Given this list of marker genes NUP133 (NCBI Gene Id 55746), SMC6, PML, WRN, NUP54, NUP43, POM121C, TDG, NUP50, NUP85, STAG2, SEH1L, NUP93, SEC13, PHC1, NUP37, PIAS1, BRCA1, NSMCE1, EID3, NUP160, SMC5, PHC3, NUP155, PIAS2, UBE2I, SUMO3, NUP42 (nucleoporin 42), NUP35, CETN2, SUMO2, SUMO1, NUP205, NUP62, RAD21, NUP98, PHC2, BLM, TPR, PARP1, CBX8, NUP153, RAD52, NSMCE4A, NUP188, NUP58, RANBP2, SMC1A, CDKN2A, SP100 (NCBI Gene Id 6672), NUP214, NSMCE3, STAG1, MDC1 (mediator of DNA damage checkpoint 1), RNF168, NUP88, CBX4, XPC, SMC3, NUP210, RING1 (NCBI Gene Id 6015), CBX2, HDAC7, RNF2, RAE1, SCMH1, AAAS, PCGF2, HERC2, NSMCE2, BMI1 (NCBI Gene Id 648), POM121, PIAS4, XRCC4, NUP107, RPA1, NDC1, here is a description of the gene set: studied in species Homo sapiens Human Gene Set: REACTOME_SUMOYLATION_OF_DNA_DAMAGE_RESPONSE_AND_REPAIR_PROTEINS SUMOylation of DNA damage response and repair proteins